Given this list of marker genes Cacna1g, Pml, Cacna1c, Ffar1, Epo, Bmp4, Cav1 (NCBI Gene Id 12389), Trpc3, Asph, Slc8a2 (solute carrier family 8 (sodium/calcium exchanger), member 2), Cacna1i, Adcyap1r1, Bax, Adra1a, Cacnb3 (calcium channel, voltage-dependent, beta 3 subunit), Trpv5, Gimap5, Akap5, Bcl2, Bak1, Grin1, Gimap3, Tmbim6, Lhcgr, P2rx7, Slc8a1, Cd4, Oga, P2rx4, Slc8a3, Cacna2d1, Ryr2, here is a description of the gene set: Mouse Gene Set: GOBP_CALCIUM_ION_TRANSPORT_INTO_CYTOSOL The directed movement of calcium ions (Ca2+) into the cytosol. species: Mus musculus